Given this list of marker genes STXBP1, TRIM8, CASK, ROGDI, GRIN2A, PNKP, CELF2, SCN2A, NTRK2, SZT2, CLCN4, DENND5A, SLC9A6, DPM2, GLS, GABRB2, SLC2A1, KCNB1, CYFIP2, GLUL, GABRG2, FRRS1L (NCBI Gene Id 23732), GRIN2D, CHKA (choline kinase alpha), SLC6A1, SLC1A2, ARV1, HNRNPU, KMT2E, GABRB1, CAD, KCNT1, HNRNPR, UBA5, AP3B2, PACS2, GABBR2, DNM1, ARHGEF9, KCNA2, CACNA1B, DOCK7 (dedicator of cytokinesis 7), SLC32A1, POLR1A, RNF13, GABRA1, FGF12, SYNJ1, PAFAH1B1, KCNA1, PIGA, NAPB, DNM1L, AFF3, ST3GAL3, TWNK, KCNH5, SCN8A, NECAP1, SLC13A5, PIGQ, SLC25A12, CDKL5, SPTAN1, DHDDS, CUX2, CHD2, CRLS1, KCNC2, SLC38A3, DCX, DPAGT1, PNPO, ZNF668, SCN1B, AP2M1, GRIN1, SLC25A22, PIGP, KCNQ5, PLCB1, MEF2C, GRM7, EEF1A2, NEXMIF, UGDH, COQ4, GNAO1, CNPY3, MAST3, GUF1, PARS2, KCNQ2, PPP3CA, CACNA2D2, MDH2, NRXN1, STAG1, SCN1A, NSF, TBC1D24, ATP6V1A, DMXL2, SYNGAP1, CACNA1A, FCSK, GRIN2B, WWOX, SCN3A, PHACTR1, AARS1, NUS1, CARS2 (cysteinyl-tRNA synthetase 2, mitochondrial), GABRB3, TRIT1 (NCBI Gene Id 54802), ALG9, PMPCB, NEUROD2, SIK1, ARX, CACNA1E, ADAM22, KCNT2, SLC35A2, CPLX1, MDH1, BOLA3, HCN1, here is a description of the gene set: species: Homo sapiens Human Gene Set: HP_EPILEPTIC_ENCEPHALOPATHY A condition in which epileptiform abnormalities are believed to contribute to the progressive disturbance in cerebral function. Epileptic encephalaopathy is characterized by (1) electrographic EEG paroxysmal activity that is often aggressive, (2) seizures that are usually multiform and intractable, (3) cognitive, behavioral and neurological deficits that may be relentless, and (4) sometimes early death. Epileptic encephalopathy